Given this list of marker genes DR1, MTCL3, NFYB, PSG2, APBB2, POLQ, MTHFD1, TAF5, QRICH1, CLEC1A, EPHA5, HS3ST2 (NCBI Gene Id 9956), OMG, INPP4A, TMEM252, CHD3, SAR1B (NCBI Gene Id 56680), LIAS, HEATR4, KDM5B, TRMT61B, ZNF451 (NCBI Gene Id 80822), THAP10, PSG11, KLF7, MPHOSPH9, RBM48, STAM, PDE12, SCG2, SMIM7, MGAT4A, TNFSF4, LRCH1, MIA3, CAMK4, WDR31, RAB31, RXFP1, ELOVL6, DMTF1 (NCBI Gene Id 9988), PCDHA9, SNAP47, TLR7, HIPK3, SPATA13, ARIH1, ADGRF2P, ARX, MTTP, FBXL4, PLSCR1, PIK3C3, TNFAIP3, ANO5, GPR155, DIO2, TMEM260, PKD2L2, MATR3, SLC8A1, CLEC2A, VAMP3, SOS1, PTPRR, PAQR8, RANBP6, COQ6 (coenzyme Q6, monooxygenase), UBL3 (NCBI Gene Id 5412), C1orf21, KBTBD2, DAP, TRIO, STYK1, ERO1B, YEATS4, WDR36, ZNF780B, PGK1, EFEMP1 (NCBI Gene Id 399564), SLC45A4, SPRTN, SUV39H2, AKAP6, DTNA, CDC27, DYRK3, RCBTB1, C17orf75 (NCBI Gene Id 64149), PSG5, ZCCHC7, PRRG1, TMCC1, RBPMS, SPMIP6, ERC2, RAD51B, MAPK10, CPEB2, KCNQ5, NLGN1 (neuroligin 1), IDE, EID2 (EP300 interacting inhibitor of differentiation 2), PSG3, CFAP65, NFE2L3, PPP2R1B (NCBI Gene Id 5519), FAM13B, MOSPD2, GRIA3, PPM1B, PRICKLE2, RREB1, ERH, RAP2C, TMC5, COQ10B, ZFC3H1, BCAT1, STRADA, MYF5, GINS4, TAFA1, NCAM2, RAD51AP1, PCSK6, BRCC3, CEACAM8, UCHL5, ZNF12, KLHL1, PHACTR4, CUX1 (cut like homeobox 1), GRAMD1C, here is a description of the gene set: studied in species Homo sapiens Genes predicted to be targets of miRBase v22 microRNA hsa-miR-4635 in miRDB v6.0 with MirTarget v4 prediction scores > 80 (high confidence targets). from publication Chen Y, Wang X (PMID 31504780) Human Gene Set: MIR4635